Given this list of marker genes RPL29, RPL18, RPL23, PPIA, RPS8, RPS11, RPL6, RPL35A, RPS7, UBA52, NPM1, RPS2, RPS3A, TPT1, RPL17, RPL13A (ribosomal protein L13a), RPL4, RPL34, RPL35, RPL27A, ATP5MC1, RPL10A, RPSA, RPS17, CFL1, RPL38, RPS21, H3-3A, RPL7, RPL14, RPS16, NDUFA12, RPL21, RPS29, RPS28, ATP5PB, NCL, SLC25A6, RPS9, RPS14, RPS27A, RPL32, RPS3, RPS19, RPS23, EEF2, EEF1G, RPL9, RPLP2, RPL19, RPS18, RACK1, RPL31, EPRS1, RPL3, RPS6, NACA, CLEC18C, RPS25, RPL7A, RPL36A (NCBI Gene Id 6173), RPL27, RPS10, SLC25A3, RPLP0, RPL11, RPL23A, RPLP1, RPL28, RPS24, here is a description of the gene set: Neighborhood of TPT1 tumor protein, translationally-controlled 1 in the GCM expression compendium Neighborhood of TPT1 species: Homo sapiens Human Gene Set: GCM_TPT1